Given this list of marker genes NOS3, ADK, POLG, CIITA, ZAP70, DDOST, SLC19A2, NUMA1, ATP6V1B2, OSTM1, TBC1D24, ANK1 (NCBI Gene Id 286), BCL11B, GNE, MTAP, DNMT3A, RBM10, GATA2, TAFAZZIN, LPIN1, NKX2-5, H4C9, JPH2, ETHE1, DMD, USP18, SLC25A38, PEX3, IRAK1, TPI1, LRPPRC, FANCM, DEF6, CLPX, LARS1 (leucyl-tRNA synthetase 1), HTRA2, PTEN, SERPIND1, IGLL1, CDKN2C, OCRL, COL4A1, PRKCSH, RPL11, MYRF, ELANE, RBPJ, RASA1, MPDU1, SCO2, NHP2, KCNN4, KCNE5, HPGD, KCNJ3, FLII, HSD17B10, RPL26, CD55, DBH, MYLK, ICOS, RAD54B, NDUFB7, TTC7A, DES, SAMD9L, FAS, HPRT1, SMAD3, NLRP12, SRD5A3, C3, PIK3CA, CACNA1S, ADH5, PLCG1, FIP1L1, NSMCE2, DIAPH1, STX11, GNAQ, NFKBIA, TLR3, ITGB2, CFHR1, RPS7, PRORP, NR1H4, XK, MT-ND6, ATP6V0A2, EFEMP1, KLF11, PHF21A, CFTR, PALB2, TNFRSF4, VPS13B, EXTL3, MRAS, FERMT1, KRT5, CYBA, NAA10, RPS17, EFL1, LRP5, MECP2, HMCN1, ELN, PLEKHM1, PYCR1, MCFD2, MT-ND4, HBG1, JAZF1, UBE2A, NOD2, FANCB, MYBPC3, TNIP1, UBA2, AXIN1, CBLIF, FMO3, PIGT, IL10RA, AP3D1, ARL6IP6, PPT1, PLA2G4A, SRP54, BSCL2, FGF23, MTRR, DNAJC3, STN1, RPL35A, OTUD5, TSPAN12, SEC61A1, TGFB1, FERMT3, CREB3L1, ARVCF, TPP2, ITK, HLA-B, COX10, CLPB, ATP7B, CCR1, GJA5, TBK1, PHOX2B, ATP11A, PAX2, PLG, PGM3, SMAD4, RAG2, PCNT, ERCC6L2, FBN1, SHOC2, CRIPT, TREM2, MT-ND5, NAGS, LAMB3, XPR1, ELF4 (E74 like ETS transcription factor 4), COX4I2, ATP6V1E1, SDHA, ALMS1, TERC, ETV6, NUP155, FUT8, VPS45, CDC40, RET, GCSH (glycine cleavage system protein H), AARS1, DGCR2, TBX2, ALG8, POT1, SEMA4A, SOS1, MSN, THRA, CD36, MYL4, PML, TFR2, FGA, KIF20A, FDX2, MT-TF, PCCB, HADHB, FGFR2, MT-TL1, BLNK, IGKC, CACNA1D, TKFC, TBL1XR1, TICAM1, ASL, MT-CO1, CYB561, RPL15, G6PC1, CR2, RNF168, ALDOA, NCF1, DDX41, HMBS, SCN11A, USP8, COL4A2 (collagen type IV alpha 2 chain), FOXN1 (forkhead box N1), MMAB, DHPS, PKHD1, CASP8, TNFSF15, ANKRD26, NSMCE3, HSPA9, SPINK1, SC5D, BCL11A, SPI1, PRTN3, XYLT2, RASGRP2, CBL, TNFRSF11A, LIPA, SGPL1, SFXN4, SRP19, BCR, MTTP, F12, GALT, CYB5A, JAK2, SARS2, POLE, PDGFRB, SEC63, TFRC, RPS27, PRKCD, C2, DCLRE1C, CD3E, CTPS1, ZBTB7A, POMP, CD81, ATR, GATB, ZNF408, KNG1, HK1, BUB1, PRKG1, MAN2B1, GNB2, NEUROD1, RELB (NCBI Gene Id 5971), USB1, HAND2, SCN5A, NLRP3, CYP11B2, RAC2, NF2, CLN3, TRIM28, ISCU, TP63, MT-TS2, IKZF1, CITED2, SLC7A7, PPCS, PMS1, BCL6, PRPS1, TNFRSF13B, F8, IFNGR1, SETX, AK1, PTH1R, SP110, PSEN1, UBE2L3, SUFU, MT-CO2, FAH, MMP1, AHCY, PRKACB, PRSS1, MGAT2, SLC30A7, CEBPE, FOXP2, ATRX, IGHG2, FLI1, NGLY1, ATM, SLC25A21 (solute carrier family 25 member 21), MLH1, FOXP3, COG2, HPS4, ACAT1, IVD (isovaleryl-CoA dehydrogenase), IL2RB, BLOC1S6, GCLC, ZNF469, UHRF1, C2orf69, BRD4, ALG9, CDC42, HLCS, MSH2, RAD51, ALG13, CLCN7, GNA14, MALT1, KRIT1, DOCK11, CRYAB, PEX6, HELLPAR, DKC1, IL12RB1, CLN5, RAD54L, LIG3, FKTN, EXT2, PNP, CYP2C9, NFE2L2, NCF4, ATP11C, RNF113A, COL2A1, KIF15, CDKN2A, SCARB2, CYP4F22, SH2D1A, RB1, CDSN, CYP2A6, GLI1, CHIC2, INS, TGFB3 (NCBI Gene Id 7043), DTNBP1, RHOH, CD109, SAA1, CSF3R, PIK3CD, TF, MDH2, SPINK5, VKORC1, KCNJ1, NIPBL, LRRC8A, IGHM, MUC1, C1QB, MDM2, AMACR, MRTFA, BAG5, FANCF, SERPINC1, DPM2 (dolichyl-phosphate mannosyltransferase subunit 2, regulatory), RPL35, RPS29, BUB3, ALG6, BRAF (B-Raf proto-oncogene, serine/threonine kinase), EGLN1, MCM4, TREX1, PLOD1, RPS15A, LCAT, DGUOK (deoxyguanosine kinase), EDNRB, AMN, LRBA, CYP26C1, LMNA, SON, COG1, STT3B, AICDA, GUCY1A1, WDR1, MAP2K1, IL12A, ZNF341, ABCB6, GATC, MBD4, SKIC3, BAX, ERCC6, ZBTB16, MAP1B, BIRC3, CCNO, CD79B, EGFR, IRX5, MADD, ABCG8, WIPF1, SLC5A6, TCAP, TOM1, SIN3A, DSE, TMEM237, ZNFX1, TBX21, SNORD118 (small nucleolar RNA, C/D box 118), CD3D, LYRM7, LMBRD1, SNX10, PTPRC, B3GALT6, MYSM1, SHARPIN, IRF2BP2, ADAMTSL2, VPS13A, ASAH1, DIS3L2, STK4, C1GALT1C1, WDR19, UBAC2, ACTN2, BRCA2, PSMC1, WARS2, TPM4, PLVAP, PSAP, ARG1, IFIH1, HLA-DQA1, SERPINE1, ACTN1, PRDM5, MT-CO3, UQCRFS1, GLRX5, DPP9, RPL5, UNC13D, TLL1 (NCBI Gene Id 7092), IKBKB, COL5A2, IL10, ACTA1, GFI1B, RFX5, BACH2, DUT, RBCK1, EMILIN1, IL12B, HOXA11, CORO1A, PEX19, CYP11B1, LCP2, VWF, PIGM, PUF60, UMPS, IRF8, XRCC2, CFI, HMOX1, ABCC2, POU2AF1, FLT3, CEBPA, SPRED2, IL12A-AS1, DNAJC21, VEZF1, MEFV, MPIG6B, EPHB4 (NCBI Gene Id 2050), PRKDC, PIK3CG, ERCC8, TCIRG1, ENG, JMJD1C, TAF1A, GNA11 (NCBI Gene Id 93626), DOCK8, PSMG2, TMEM147 (NCBI Gene Id 84721), GREM1, LMAN1, COL1A1, GIMAP5, FBXL4, TLR4, TAL2, DNAJC19, DCDC2, SLC4A1, LSM11, CAD, PTF1A, NLRC4, TERT, SASH3, CDKN2B, FIG4, CTC1, PRDM16, BLK, CP, RMRP, TSC1, CXCR2, CDC42BPB, ALG1, SFTPA2, ITGA2, GATA3, FLT1, RAF1, SDHD, RPL31, TNFRSF1B, TXNRD2, FARSA, RREB1, KHK, ERCC3, BRCA1, NCF2, PKLR, TNFRSF1A, SEMA4D, SBDS, FARSB, ETS1, KARS1, PROS1, RFWD3, TNFAIP3, CD3G, SLC2A10, ANAPC1, TOR1A, SHPK, RPL8, SMARCE1, RIPK1, F11, LAT, NBN, ALAS2, COPA, FTH1, NFKB2, HMGCL (NCBI Gene Id 3155), CARD9, RNU4ATAC, SAR1B, SPTA1, GPC3, KCNJ11, BMPR1A (bone morphogenetic protein receptor type 1A), CLCNKB, ALG2, P2RY12, LAMB2, CA2, XYLT1, TTI2, DNM2, TALDO1, RACGAP1, PRSS2, MEN1, PDCD10, GPI, MECOM, PEPD, ATP6AP1, ABHD5, GNAS, IKBKG, SAMHD1, USP48, ACP5, PDGFB, MTHFD1, OPA1, CSRP3, FIBP, FH, BTNL2, EWSR1 (EWS RNA binding protein 1), F9, ABCB7, PLOD3, NR3C1, SYK (spleen associated tyrosine kinase), HAVCR2, ATIC, CASK (calcium/calmodulin dependent serine protein kinase), SLC25A15, VCL, HEATR3, MVK, PEX1 (NCBI Gene Id 7788), BPGM, PBX1, CPT2, COQ2 (coenzyme Q2, polyprenyltransferase), UNG, DNM1L, DGKE, NOTCH3, CHST14, APP (amyloid beta precursor protein), RNF31, SLC51A, HNF1A, NCKAP1L, PHGDH, FBXW7, GAA, SLC37A4, TRIP13, MUTYH, RPGRIP1L, MARS1, SRSF2, ARHGAP26, HLA-DPA1, IL21, MAP3K14, NKX2-6, TONSL, CYB5R3, DHFR, ADAM17 (NCBI Gene Id 6868), GP6, IL18BP, NPC2, RNF43, CYP27B1, LBR, C4A, REN, MS4A1, TET2, ITPA, SLF2, MYD88, SLC19A1, IFT140, CSNK2A1, IDH1, SLC11A2, WRAP53, TARS1, CEL, MT-CYB, NFKB1, STAT2, EOGT, RBM20, NOP10, MTOR, MST1, ESS2, SALL4, FANCA, SRP68, ARFGEF2, VPS33A, KDM6A, CYCS (NCBI Gene Id 54205), DOCK6, FN1, SOS2, AGK, RPL13, SERAC1, DEAF1, ZPR1, OTC, KLKB1, IRF4, RFT1, SDHC (NCBI Gene Id 6391), AMMECR1, THPO, MYH6, SMARCB1, MMEL1, GNB1, ARPC5, TRMT5, SCN3B, HYOU1, PGK1, PEX13, IL1RN, MRPS7, ALAD, PI4KA, CUBN, GP1BA, PHKG2, RNASEH2A, ABCD3, RNASEH2C, GLB1, NABP1, IREB2, CBS, PXK, POLD3, TTN, DOLK, CYSLTR2, PRDX1, BAP1, CD40LG, MPLKIP (M-phase specific PLK1 interacting protein), RBM8A, TPM1, LPIN2, HPS6, IRF5 (NCBI Gene Id 84729), KLHDC8B, YIPF5, CNTNAP2, CTRC, CEP57, MTX2, RPL9, PTPN2, TSR2, NEDD4L, ITCH, PIGL, LAMA3, RPS14 (NCBI Gene Id 6208), AKT1, PITX2, DNASE1L3, LEP, PTPN6, HGD, TMPRSS6, BLM, PROC, TNNC1, NPHP1, SCN1B, TPMT, ADAMTS3, SLCO2A1, SMAD2, EPO, TINF2, SOCS1, NEK8, GSS, SKIC2 (NCBI Gene Id 6499), AAGAB, PSMB9, FOCAD, MT-TQ, CD46, HABP2, SCN2B (sodium voltage-gated channel beta subunit 2), CTNNB1, DLST, EPHB2, GCDH, ATP5F1A, SUCLA2, FUCA1, VPS33B, DPAGT1, CNBP, ADA, HPS3, APOA1, PTPRJ, ERMARD, PEX12, KRAS, AEBP1, STAT6, PRLR, SLX4, ICOSLG, RAD50, CLCN2, RPL3L, CARD11, STK11, MLX, DYNC2LI1, ASXL1, CCND1, ATP7A, PEX5, TMEM67, NDP, SLC4A4, BRIP1, CDH23, MICU1, PRKACA, ADA2, CARD10, NARS2, GPX1, ABCG5, ERCC4, MARS2, PUS1, NRAS, HPS1, NFS1, PRF1, IGHG1, G6PD, FTCD, COL1A2, DZIP1L, ANKRD55, CD19, TRAF3, ESCO2, RASGRP1, MOGS, SLC40A1, RPL27, STXBP2, COG6, SLC35C1, ZNF699, PPIL1, MFAP5, ADAMTS13, NLRP1, B4GALT1, MAX, SRP72, IKZF3, COL14A1, IFNG, TP53, ABCC8, LMOD2, ACAD8, NAGA, ATP6AP2, ALK, PSMB4, MMAA, IL2RA, TMPO, MYC, IL6ST, TNXB, KIF1B, NSD1, MAP2K2, PTPN11, NEXN, BCOR, COG8, ADAR, BRCC3, MTR, FOXP1, TYK2, JAGN1, NBEAL2, SEC24C, SETBP1, KMT2D, PTPN22, DSP, NCAPG2, NOTCH1, STXBP1, IDH2, TNFRSF13C, FGB, PDE11A, MYCN, CHD7, DLD, LDB3, SGCD, ALX4, SF3B1 (splicing factor 3b subunit 1), GALE, CD40, TNFSF12, RINT1, VHL, SH3KBP1, SLFN14, TLR7, ACVR1, FARS2, NDE1, CCM2, FZD4, RPS10, FCGR2C, AGXT, CCBE1, MYH7, ACD, TYROBP, LETM1, FECH, BLOC1S5 (NCBI Gene Id 63915), LAMC2, STIM1, H19, NAE1 (NEDD8 activating enzyme E1 subunit 1), MPL, SLC35A1, SLC2A1, CTCF, OCLN, ACBD6, NSD2, FAT4, PNPO, C1R, NSUN2, LZTR1, PRKACG, FLNA, NF1, SLC46A1, NUP214, STS, CREBBP, ATPAF2, FNIP1, MDM4, NAF1, LCK, MT-TH, MAGT1, SERPINF2, GALC, RANBP2 (RAN binding protein 2), DNASE1, TEK, F13A1, DCLRE1B, FOXE3, GATAD1, GYPC, RAG1, POU6F2 (POU class 6 homeobox 2), RASA2, RAI1, RAD51C, FASLG, G6PC3, GINS1, MT-ND1, IL17RA, COL17A1, CD27, BTK, ABCD4, ARMC5, RFXANK, LPP, CDKN1B, SEC23B, CAPN3, TGFBR1, BUB1B, BANK1, OAS1, CISD2, CD4, FANCI, RHCE, UBE2T, TMEM165, IL2RG, C1S, CYP2R1, TCN2, AGR2, AGGF1, ALPL, EPG5, ERBB3, PDCD1, CALR, APOE, ABCC6, PHKB, NT5C3A, PCCA, BMPR2, GSN, KIF23, CD70, DNMT3B, NBAS, ALB (NCBI Gene Id 29004), MYPN, F2, NPPA, MAT2A, NHEJ1, MED12, STEAP3, MET, TRPV6, GTF2H5, ITGA2B, KCNJ2, CTNNBL1, GATA4, RYR1, MMACHC, MLLT10, COL7A1, RPL18, UNC119, EPB41, LYN (NCBI Gene Id 4067), KLF1, PIGA, THSD4, GPR35, PEX26, ARHGAP31, SCN9A, ANO6, SURF1, PEX10, GLA, NPHP4, SMPD1, TDP2, GATA1, KCNE2 (potassium voltage-gated channel subfamily E regulatory subunit 2), AASS, ACTA2, STAT3, RPS24, EPB42, WRN, RPS20, FHL2, IL37, COL4A5, ZEB2, BGN, RHBDF2, AFG2A, APPL1, ACTN4, FCGR2A, HADH (hydroxyacyl-CoA dehydrogenase), RNU7-1, SREBF1, FCHO1, F7, GATA5, GPC4, LIG4, HCK, RAP1B, CORIN, GFI1, SPTB, HBA2, STAT1, PACS2, SAMD9, TNFSF4, LAMA4, MYORG, TYMS, CAP2, UNC45A, FANCD2, PLCG2, MPV17 (mitochondrial inner membrane protein MPV17), FAM111A, CPA1, PFKM, WFS1, XIAP, B2M, ACSL4, CFH, ARHGEF1, ANKRD1, MUC5B, PLN (NCBI Gene Id 5350), GALK1, KRT1, TTR, SDHAF2, PLAAT3, ZBTB20, KRT74, PPOX, ANGPTL6, NFIA, HSD3B7, ARPC1B, PRKAR1A, TIMM8A, SMARCD2, MYH9, TUBB1, SFTPC, RRAS, ORAI1, CXCR4, ITGAM, HSCB, CD247 (CD247 molecule), NAXD, TGFBR2, LEPR, APC, HEY2, IL23R, LMO1, COL5A1, DOCK2, EPCAM, LYST, CBLB, IL36RN, AP1S3, MMUT, UFD1, F10, XRCC4, IPO8, STX5, IKZF5, ERCC2, LIG1, DGCR8, DRG1, QRSL1, MCTS1, CELA2A, TRNT1, HBB, RUNX1 (NCBI Gene Id 861), CST3, TGFB2, DNASE2, SDHB, IL7, CYP7B1, CHEK2, NELFA, ENPP1, NHLRC2, GDF2, SRC, KLRC4, PEX14, LOX, HBD, DSG2, TAL1, SLC27A4, UBA1, WAS, SLC5A2, CYBB, STING1, GET3, BCL2 (BCL2 apoptosis regulator), TNNT2, MAD2L2, HLA-DRB1, PARN, EPAS1, MT-TN, LMX1B, BMS1, UBR1, PDGFRA, KANSL1, IRAK4, GP9, EVC, CTLA4, POLD1, ELMO2 (NCBI Gene Id 63916), CDKN1A (NCBI Gene Id 1026), COA8, NEU1, SPP1, HNF4A, RHAG, TMEM127, PLEC, FKBP14, RIN2, PANK2, FYB1, CYBC1, CTBP1, SGCG, YARS1, CDCA7, AIP, RRM2B, GALNT2, CFHR3, TCF4, STAT5B, TGFBR3, KRT14, NTRK1, HBA1, TAOK1, CD79A, HLA-DQB1, CASR, MCM10, FANCE, APOB, PIEZO1, UNC93B1, COG4, LACC1, JAK1, FADD, RPSA, ACAD9, ALG12, STT3A, C4B, CDAN1, TNNI3, AP3B1, JAM2, EVC2, PSTPIP1, GTF2E2, SLC25A10, BICD2, TCF3, ABCA1, ADAMTS2, MSH6, NTHL1, PNPLA2, TBXA2R, RPS19, JAK3, ALPK1, BLOC1S3, GGCX, ERAP1, RRAS2, KCNE1, FCGR2B, CPLX1, NFIX, TBXAS1, ALDOB, PIK3R1, SLC30A10, KRT9 (keratin 9), ITGB4, CAMK2B, SMC5, ALG3, RTEL1, AK2, ACTC1, TLR8, NDUFA6, SLC39A13, IRF1, SLC39A4, NUTM1, HELLS, COX16, APOLD1, HAX1, IL6R, NPC1, KIAA0319L (KIAA0319 like), LARS2, HRG, EPX, LAMTOR2, TRMU, CARS1, PEX2, FCGR3A, SLC12A3, UROD, HIRA, RS1, MTHFR, AKR1D1, SCN4B, FANCL, KIF11, WT1, CFB, EP300, HACE1, MPI, GSR, RARA, MT-TW, KCNQ1, TBCE, GP1BB, PLAU, KCNA5, MMADHC, ACVRL1, ITGB3, PDX1, NPM1, SLC25A13, ATP8B1, UROS, PRIM1, MYH11, CAPN5, SLC25A11, PMS2, P4HA2, SMARCAL1, FCGR3B, PHKA2, REL, MPO, CDIN1, ABL1, SSR4, DPM1, KCNK3, TBX1, SMO, PAX4, CARMIL2, COL3A1, THSD1, F5, RPS28, GBA1, SAT1, KCNJ5, PMM2, SPPL2A, SLC29A3, STOX1, GATA6, CD59 (NCBI Gene Id 966), EIF2AK4, CASP10, AGA (NCBI Gene Id 175, aspartylglucosaminidase), THBD (thrombomodulin), IQSEC2, THBS2, KNSTRN, HAMP, ZMPSTE24, GCK, LIN28B, RIT1, FGG, BAG3, FANCC, RFXAP, IL7R, SIK3, ARF1, NFATC2, SPRED1 (sprouty related EVH1 domain containing 1), ZFX, TNFRSF9, DLL4, FANCG, IVNS1ABP, SLC39A7, PGM1, CAT, EPOR, ACTB (NCBI Gene Id 60), KIT, PSMB10, HLA-DPB1, LMNB2, CAVIN1, PICALM, SH2B3, ESAM, SLC4A2, TMTC3 (NCBI Gene Id 160418), OTULIN, KDM1A, ATP6V1A, DSG1, COMT, DGCR6, PET100, LYZ, DMXL2, CD8A, HBG2, ZCCHC8, APC2, RNASEH2B, REST, RPA1, ANKRD11, OBSCN, CD28, CPOX, BCL10, PSEN2, SH3GL1, FLNC, YARS2, SPIB, PEX16, SERPINA6, SLC20A2, RAB27A, MICOS13, RECQL4, HPS5, MAPK1, TSC2, ABCC9, PIGG, RECQL, TRAF7, DST, STAT4, POLRMT, TYMP, TNPO3, TNFSF11, SCN10A, CRELD1, CTNS (NCBI Gene Id 1497), TUBA8, SPARC, RPS26, F13B, TRAC, ZBTB24, PEX11B, EIF2AK3, RHD, PSMB8, IL21R, SLC17A5, BEST1, ATOH7, here is a description of the gene set: Human Gene Set: HP_ABNORMALITY_OF_BLOOD_AND_BLOOD_FORMING_TISSUES Abnormality of blood and blood-forming tissues species: Homo sapiens An abnormality of the hematopoietic system.